The following is a description of a gene set: Human Gene Set: GOCC_COPII_VESICLE_COAT One of two multimeric complexes that forms a membrane vesicle coat. COPII is best characterized in S. cerevisiae, where the subunits are called Sar1p, Sec13p, Sec31p, Sec23p, and Sec24p. Vesicles with COPII coats are found associated with endoplasmic reticulum (ER) membranes at steady state. species: Homo sapiens, and this is the list of marker genes: PDCD6, CIDEB, SEC13, SEC23A, KLHL12, SEC24C, SAR1A, SEC24D, SEC24A, SEC23B, SAR1B, SEC31B, SEC24B, SEC31A, TMED7, PEF1